Given this list of marker genes PLA2G2A, PYGM, STING1, CD27 (NCBI Gene Id 939), ATPAF2, GTF2IRD1, FCGBP, C4orf46 (NCBI Gene Id 201725), ABHD11, SPATA41, RGS16, NT5E, CCL7, GCSAM, KLRD1, SLC22A16, SYCE2, IFIT1, TRIM69, SIAH3, CCL2, ZSCAN23, ZBED2, PCDH20, GPR88, MS4A8, DUSP10, EDNRA, MIR646HG (NCBI Gene Id 731761), BACH2, COL4A5, PRAMEF11, RBMXL1, RAPGEF2, UTF1, CCL20, RHEBL1, APOBEC4, ADGRL2, TMEM213, MTSS1, CYP3A5, SOX18, DNASE1L3, DNAJB13, ODAD2, PDGFA, FAM171B, SLC10A2, IFNA17, LYST, IFIT5, SYTL2, SMOC2, PKP3, PASK, CXCL8, ACTRT2, TBX21, DUSP16, WDTC1, CD207, STAG3, IFI44L, MRAS (NCBI Gene Id 654181), EXOG, OASL, ZNF517, RAMP2, FAM107B, MEX3C, KLHL15, SOCS2-AS1, IL12RB2, CCNA1, GRIN2B (NCBI Gene Id 2904), SPATA12, NOTCH1, COL6A3, TNFSF13B, IL2RB, LINC00955, LEFTY2, LINC01270, MYL7 (myosin light chain 7), FGF13, IL1B, EFHC2, MIR3945HG, SGK1, GPR155, NIM1K, PIM2, CSHL1, GIMAP4, SCRT1, ANKRD31, EGFL7, HARBI1, ALPK1, ZDHHC14, TFPI, TTLL6, GIMAP6, DAO, SNX9, CD82, BCL6, APOBEC2, SLCO1C1, WNT10B, TGIF1, TCEAL9, ZNF619, JUNB, SPMAP2 (NCBI Gene Id 91957), GPR6, LGALS9, NIPSNAP3B, SLC27A2, HVCN1, SH2D5, TNFRSF1B, VWF, GABRB1, SERPINE2, BICDL1 (BICD family like cargo adaptor 1), ENPP2, THSD7B, RDX, CD5, RNF126P1, HDAC9, PIN1P1, BAG3, CTLA4, GPIHBP1, VAV3, IFNA16, P2RY14, TYMP, DDIT4, RHOU, C21orf58, OR2C1, ADGRE5, ITGB8, CARD11, ATP1B1, COL15A1, DSG3, CD74, BMPR1A, PRKXP1, LINC01144, MAST4, CR1, S100A3, KCNJ9, GBP4, PDK2, POLL, KRTAP7-1, IL21R, SLCO2A1, ANKAR, PALLD, GBP5, SCGB2A2, DSC1, CD28, TEX35, TEX13B, HYKK, IPCEF1, USP26, KIR2DL4, CDH3, ULK4, RAD51AP1, GUCA2A, LRRC75B, CLCA1, MYO6, SRD5A3, CFAP184, ZNF771, ALDOB, SDCBP2, UGT2B15, here is a description of the gene set: Genes down-regulated in comparison of CD4 T cells treated with IL4 and anti-IL12 at 12 h versus the untreated cells at 12 h. The aim of this dataset was to study in detail the transcription kinetics initiated by cytokine IL-4 in early differentiation of Th2 cells. Human Gene Set: GSE17974_IL4_AND_ANTI_IL12_VS_UNTREATED_12H_ACT_CD4_TCELL_DN from publication Elo LL, Järvenpää H, Tuomela S, Raghav S, Ahlfors H, Laurila K, Gupta B, Lund RJ, Tahvanainen J, Hawkins RD, Oresic M, Lähdesmäki H, Rasool O, Rao KV, Aittokallio T, Lahesmaa R (PMID 20620947) species: Homo sapiens